The following is a description of a gene set: studied in species Homo sapiens Genes up-regulated in comparison of dendritic cells (DC) exposed to L. major versus DCs exposed to M. tuberculosis. from publication Chaussabel D, Semnani RT, McDowell MA, Sacks D, Sher A, Nutman TB (PMID 12663451) Human Gene Set: GSE360_L_MAJOR_VS_M_TUBERCULOSIS_DC_UP Monocyte-derived dendritic cells (DC) and macrophages (MΦ) generated in vitro from the same individual blood donors were exposed to five different pathogens, and gene expression profiles were assessed by microarray analysis. Responses to Mycobacterium tuberculosis and to phylogenetically distinct protozoan (Leishmania major, L. donovani, Toxoplasma gondii) and helminth (Brugia malayi) parasites were examined, each of which produces chronic infections in humans yet vary considerably in the nature of the immune responses they trigger., and this is the list of marker genes: UQCRH, COX5A, TTLL5, AKAP8L, CELF3, GTPBP6, RHOQ, APOC3, SLC25A1, NXPH4, PGAP4 (post-GPI attachment to proteins GalNAc transferase 4), ASAH1, TCEAL4, CLNS1A, MYCNOS, TAF1B, PLAAT4, MYH3, INSL4, IGHE, ABCG1, ALOX15, CLDN4, PTPRA, RRAS2, JRK, RAB33A (RAB33A, member RAS oncogene family), PPP1CC, GRM5, MGRN1, BAG1, KDM4C, SLC35D1, PLK3, TMED3, CRISP1, CHST7, CCNYL7, IGBP1 (NCBI Gene Id 3476), CD302, GABARAP, TPPP, SEMA4D, COX4I1, MMP1, MDH2 (malate dehydrogenase 2), MRPL9, EEF1B2, RPL30, DDX51, DIDO1, MACROH2A1, MEF2C, FOLH1, SMARCA4, TIMP2, ZNF451, FRAT2, RRS1, AQP3, PPIF, SLURP1, TM4SF5, CYP7B1, CGRRF1, H6PD, AP1B1, VPS8, HOMER3, PPFIBP2, CLK1, GPNMB, VEGFA, CNOT3, PPP1R15A, KIF3C, RPS6KA2, COL7A1, CPLX2, PCBP1 (NCBI Gene Id 5093), UROS, ARL4C, SMIM10L1, TSPAN4, TOB2, PRKG2, AKAP4, TM4SF1, CDK2AP1, RBMS1, SPHK2, CELF2 (CUGBP Elav-like family member 2), EBP, TLE5, CHD1, TCHH, SPATA31C2, KCNQ1, HLX, EFR3B, OPRM1, FHIT, PRRC2B, IRS1, PDLIM3, DARS1, TBC1D8, MYH6, PTMS, RALBP1, TRAF2, RNF187, RPL36A, PSD3, PCDH9, ARL2, USF2 (NCBI Gene Id 7392), H2AZ2, PFKL, TECPR2, RPL34, NREP (neuronal regeneration related protein), CARS1, TRAIP, CTDP1, TRPC2, PLEC, CACNG3, ABCC10, RPGRIP1, PTP4A2, RGS14, NIPAL3, CYB5R3, DTNB, CDC5L, KRT10, AKAP1, PANK3, PRSS23, SRY, MICU2, CALML3, SAMM50, RECQL5, INHBA, IL3RA, CUL7, PEPD, HMGB2, SSTR3, TAX1BP1, DR1, TFE3, ADRA2A, TNNC2, GPS2, AARS1, RPS23, OXA1L, RPS4X, TNFRSF11A, ZNF592 (zinc finger protein 592), RCN2, SLC6A8, PHACTR1, HMGCS2, BTG1, MAP2K2, CARM1, CBS, GPD1, FOXO3, BMX, GADD45G, FLNB, NAGA, ATG9A, DENND2B, KIAA0040, MTSS1, HLA-DPB1, SUCO, LSM4 (LSM4 homolog, U6 small nuclear RNA and mRNA degradation associated), SHMT2, VPS13B, TCF3, APOE, BDH1 (NCBI Gene Id 622), FYN, BAMBI, MDM2, IL4, ADH6, TK1, ARHGAP25, BCAM, ARFRP1, COL4A3